The following is a description of a gene set: Mouse Gene Set: GOBP_ARGININE_METABOLIC_PROCESS The chemical reactions and pathways involving arginine, 2-amino-5-(carbamimidamido)pentanoic acid. studied in species Mus musculus, and this is the list of marker genes: Fah, Ldc1, Nos2, Azin2, Agmat, Azin1, Odc1, Asl, Oat, Ddah1, Slc7a7, Cln3, Nos1, Arg1, Ass1, Slc39a8, Nos3, Nags, Otc, Arg2, Fh1, Atp2b4